The following is a description of a gene set: Mouse Gene Set: GOMF_PEPTIDOGLYCAN_BINDING Interacting selectively and non-covalently, in a non-covalent manner, with peptidoglycan, any of a class of glycoconjugates found in bacterial cell walls. studied in species Mus musculus, and this is the list of marker genes: Reg3g, Nod2 (nucleotide-binding oligomerization domain containing 2), Reg1, Pglyrp4, Ighm, Reg3a, Tlr2, Pglyrp1, Zg16, Nod1, Jchain, Hk1, Lysmd3, Reg2, Reg3b, Trem3, Reg3d, Pglyrp2, Pglyrp3, Trem2